Given this list of marker genes Polrmt, Usp29, Herc3, Blcap, Gnasas1, Plagl1 (pleiomorphic adenoma gene-like 1), Nnat, Tmem267, 3110070M22Rik (NCBI Gene Id 67304), Nap1l5, here is a description of the gene set: studied in species Mus musculus Genes containing one or more binding sites for (Zfp445) in their promoter regions (TSS -1000,+100 bp) as identified by GTRD version 20.06 ChIP-seq harmonization. Mouse Gene Set: ZFP445_TARGET_GENES from publication Yevshin I, Sharipov R, Kolmykov S, Kondrakhin Y, Kolpakov F (PMID 30445619)